The following is a description of a gene set: Human Gene Set: GOBP_ASPARTATE_FAMILY_AMINO_ACID_CATABOLIC_PROCESS The chemical reactions and pathways resulting in the breakdown of amino acids of the aspartate family, comprising asparagine, aspartate, lysine, methionine and threonine. studied in species Homo sapiens, and this is the list of marker genes: GOT1, AADAT, MAT1A, RIDA, DLST, GCAT (NCBI Gene Id 23464), GOT2, ASRGL1, DDO, PIPOX, AASS